The following is a description of a gene set: Human Gene Set: GSE45365_HEALTHY_VS_MCMV_INFECTION_CD8A_DC_UP Murine Cytomegalovirus (MCMV) infection leads to early activation of various immune cells, including B and T lymphocytes, before the actual initiation of antigen-specific adaptive immunity. This activation is partly driven by innate cytokines, including type I interferon (IFN), which are induced early after infection. The objective of this study was to address the role of type I IFN in shaping early/innate B and T cell responses to a primary acute viral infection. In order to decipher the specific impact of IFN-I on cell subsets, we performed a genome-wide expression analysis on WT splenic B and CD8 T lymphocytes isolated from C57BL/6 mixed bone marrow chimera mice. This study complements series GSE39555, which focused on early responses of NK cells and of the two subsets of conventional dendritic cells. Genes up-regulated in CD8A dendritic cells: control versus primary acute viral infection. studied in species Homo sapiens, and this is the list of marker genes: ADO (2-aminoethanethiol dioxygenase), ARFGEF1, FIS1, TMED3, RING1, GLB1, IL13RA1 (NCBI Gene Id 3597), BTN3A1 (NCBI Gene Id 11119), KIF2A, MNT, LUZP2, RFX5, NKRF, ERLIN2, NFRKB, IGHMBP2, MTMR1 (myotubularin related protein 1), RPS27A, SLC37A4 (NCBI Gene Id 84965), BLM, ATP5PO, NR2F2, GAB2, EOLA2, NUCKS1, LOXL3, OCA2, HMGN2, TRIAP1, RPA3, VPS51 (VPS51 subunit of GARP complex), GCC2, RMDN1, SAYSD1, GARRE1, BMX, YWHAQ, RASL10A, PRKAG1, ARHGEF6, WDR77, PPP1R17, INAVA, IFFO1, LRCH3, ACTR1B, TP53TG1, NARS2, PARVB, PRCP (prolylcarboxypeptidase), PRIM1, PRKD1, NDUFS7, INPP5K, HCP5, EFCAB14, CTBP1, SGSM2, MAPK14, PCYOX1L, TRAPPC9 (trafficking protein particle complex subunit 9), CCDC28A, GGH, TRIM8, PGAP2, TP53, P4HTM, ATIC, COLEC12, PHLPP2, SRRM1, RNPEP, STK16, PKN1, TBC1D22A, NIT2, SNF8, PRKACA, SPATA2, TPGS2, UTRN, SASH3, CTNNA3, BLVRA, RPS6KA1, OSBPL9, PCBD1, RBM26, UCK2, CRELD2, NCAPH, FAM20B, ECHDC3, ADAM5, BPHL, ORAI3, OS9, C1orf115, RPSA, BMAL2, UQCRQ, TRAPPC2L, MGLL, PTGES2, HLA-G, ACTG1, CAPRIN2, XPNPEP1, SLC6A12, CPPED1, SLC25A20, HTRA2, ZDHHC4, MLYCD, USP21, LMBR1L, DDX11, TERF2, TXNDC15, FADS2, MC4R, SDR39U1, PERP, WWP1, MDH2, AXIN1, RANGRF, TGFBRAP1 (NCBI Gene Id 9392), PNPLA4, SPDL1 (NCBI Gene Id 54908), MTSS1, SLC35E2B, DNAJA3, KATNB1, LAMP3, IQCE, DVL3, MPC1, CCDC92, TRAPPC12, TMEM135, MAP2K2, TTC31, OSTF1, FASTK, PKD1P6, CCNB1IP1, ANGPT4, ACY1, NUP155, ERI2, ITGB2, MCCC2, G6PC3 (glucose-6-phosphatase catalytic subunit 3), CD84, CLCN7, PHF2, GRSF1, SPON2, TYROBP, GPR153, ALG6, LSM5, FOXO1, PMPCB, PCBP1, TTC13, CALM3, SH3GL3, CD46, NRGN, HEMK1, SPECC1L, TBC1D9, TARBP1, DIS3, ANP32A, GYPC, ZNF816, ACTB, PSEN2, WIPI1, VPS16 (VPS16 core subunit of CORVET and HOPS complexes), CLEC5A, NDUFA7, VAMP1 (vesicle associated membrane protein 1), EZH1, SCNM1, TXN2, GTF3C1, TTC17, EOLA1, B4GALNT1, INPPL1, METTL16, GGA2, ARID1A, ZDHHC14, ZNF154, DHCR7